The following is a description of a gene set: RAC2 GTPase cycle Mouse Gene Set: REACTOME_RAC2_GTPASE_CYCLE species: Mus musculus, and this is the list of marker genes: Pik3r2, Cyfip1, Ophn1, Arhgap32, Rbm39, Brk1, Rab7, Lbr, Pld2, Arhgap1, Rac2, Taok3, Vrk2, Samm50, Racgap1, Vav1, Stbd1, Erbin, Epha2, Nhs, Def6, Bcr, Mcf2, Lman1, Abi1, Iqgap1, Cyba, Emd, Trio, Dock1, Vangl1, Nckap1, Mpp7, Pak1, Dock4, Arhgap39, Arhgap26 (Rho GTPase activating protein 26), Arhgap35, Pak4, Esyt1, Vamp3, Tfrc, Cdc42, Baiap2l1, Swap70, Pik3ca (phosphatidylinositol-4,5-bisphosphate 3-kinase catalytic subunit alpha), Cdc42ep4, Dock10, Garre1, Prex1, Abr, Cav1, Pgrmc2, Diaph3, Abi2, Arhgap17, Dock2, Cybb, Vapb, Arhgap21, Wasf2, Dsg2, Pak2, Slitrk5, Itgb1, Vav3, Git1, Depdc1b, Mcam, Arhgap42, Mtx1, Pik3r1, Ncf1, Nckap1l, Lamtor1 (late endosomal/lysosomal adaptor, MAPK and MTOR activator 1), Cdc42ep1, Ncf2, Arhgdia, Pik3r3, Vav2, Ncf4, Git2, Ankle2, Syde1, Armcx3